Given this list of marker genes Eif2b1, Eif1ad12, Eif1ad11, Eif3a, Eif3c, Eif1ad18, Eif4e3, Eif1ad14, Eif1ad16, Eif4a2, Dhx29, Eif2b4, Eif4b, Eif3e, Eif4e, Eif3g, Eif3i, Eif3b, Eif4e2, Eif5b, Eif4g1, Eif1a, Eif4g3, Eif4g2, Eif1ad, Eif4h, Eif2d, Eif3l, Eif1ad19, Eif1b, Eif2a, Eif1ad3, Eif5, Eif2s3y, Eif3k, Eif2s3x, Eif1ad8, Eif2b3, Eif2b2, Eif1ad7, Eif1, Eif1ad13, Eif2s1, Eif1ad2, Eif1ax, Eif1ad15, Eif3d, Eif4e1b, Eif4a1, Eif2b5, Mtif2, Eif3m, Mtif3, Eif3j2, Mcts1 (malignant T cell amplified sequence 1), Denr, Eif3f, Eif3h, Eif6, Eif3j1, Eif1ad4, Eif2s2, Eif1ad17, here is a description of the gene set: Mouse Gene Set: GOMF_TRANSLATION_INITIATION_FACTOR_ACTIVITY species: Mus musculus Functions in the initiation of ribosome-mediated translation of mRNA into a polypeptide.